The following is a description of a gene set: species: Homo sapiens Human Gene Set: HP_RETINAL_NERVE_FIBER_EDEMA Retinal nerve fiber edema Swelling (edema) of the retinal nerve fibers., and this is the list of marker genes: MT-ND6, FAS, MT-ND4L, MT-ND1, MT-CO1, NDUFS2, MT-ND4, PTPN22, DNAJC30, MT-CO3, MT-ATP6, MT-CYB, MT-ND2, MT-ND5